The following is a description of a gene set: species: Homo sapiens Combining with a cytokine and transmitting the signal from one side of the membrane to the other to initiate a change in cell activity. Human Gene Set: GOMF_CYTOKINE_RECEPTOR_ACTIVITY, and this is the list of marker genes: CCR10, IFNLR1, IL7R, CXCR6, CXCR5, IL1RAP, IL12RB2, IL31RA, IL1R2 (interleukin 1 receptor type 2), CCR8, CXCR1, CX3CR1, IL1RAPL2, IL10RB, CD44, GPR17, ACKR2, IL17RE, CXCR3, IL22RA2, CXCR4, CNTFR, IL2RA, IL13RA2, IL12B, IFNAR2, CCR2, CRLF1, IL9R, CSF2RB, IL17RB, GHR, IL11RA, IL3RA, IL18RAP, EBI3, IFNGR2, IL1RL1, IFNGR1, IL2RG, CCR7, IL13RA1, OSMR (NCBI Gene Id 9180), IL4R, CMKLR1, IL2RB, CCR6, CSF2RA, IL6ST, FLT3, IL20RA, GFRA4, GFRA2, PRLR, GFRAL, IL18R1, CCR9 (C-C motif chemokine receptor 9), MPL, IL27RA, CCRL2, IL23R, IL6R, CXCR2, IL12RB1, IL21R, CCR4, IL17RD, XCR1, LEPR, IFNAR1, CRLF2, IL1R1, FZD4, IL22RA1, GFRA3, CD74, CSF3R, IL20RB, IL1RL2, EPOR, IL10RA, IL5RA, IL17RC, CD4, GPR35, GPR75, LIFR, ACKR3, GFRA1, IL17RA, F3, CCR3, IL17REL, CCR1, IL15RA, CCR5, ACKR4